Given this list of marker genes LTN1, TBC1D15, SOX11, GPR34, MBOAT2, CDK2AP1, SCN9A, VEZT, UBE2D3, MBNL1, DCLRE1A, DNAJB5, ZNF280D, KDM7A, MPHOSPH9, CNST, HEPHL1, REPS2, GNPTAB, CYLD, SCD, CXADR, SFRP2, ZDHHC21, TCF4 (NCBI Gene Id 6925), ANKRD13A, SFRP1, POU2F1, ARL15, RAD51B, ACVR1, DDX60L, SVIP, COL25A1, MED23, RPP30, RIMS1, PRTG, HRG, CD44, TUBE1, PTPN13, EYA1, PRKCD, ASNSD1, RBM8A, ACADM, STC1, HNRNPC, ELP4, ZFAND4, POLK, SMARCA5, MAP1LC3B, MBNL3, TNFSF11, KIF14, SLC10A7, SCG3, TRMT11, PAX6, ZNF16, MYT1, CNTNAP2, FDX1, HSPA4L, CAV2, ARPC1A, RAD51, ANKRD50, RASSF8, EPHA4, HNRNPU, PPM1D, SLC7A11, BRWD1, RBPJ, PROSER2, RUNX1T1, CPSF6, APOOL, NUFIP2, XRN2, SESTD1, RGS17 (NCBI Gene Id 26575), ZBTB8B, RMDN1, WTAP, HFM1, BOD1L1, SCAF11 (NCBI Gene Id 9169), CCNA1, here is a description of the gene set: Genes predicted to be targets of miRBase v22 microRNA hsa-miR-606 in miRDB v6.0 with MirTarget v4 prediction scores > 80 (high confidence targets). from publication Chen Y, Wang X (PMID 31504780) studied in species Homo sapiens Human Gene Set: MIR606